Given this list of marker genes IGF1R, APBB2, SYNPO2, RIMS3, WSB2, LARP1B, TBC1D16, CBLB, ANKRD40, TBXT, ST3GAL3, ARL6IP5, CIRBP, KHDC4, IL13, DCUN1D4, BLOC1S5, RICTOR, NOS1, PRR3 (proline rich 3), NUP62CL, ARID2, KRAS, COL12A1, AASDH, PHIP, INO80D (NCBI Gene Id 54891), RTL5, ESYT1, BCL2L11 (BCL2 like 11), IKZF3, TANC2, ADGRL3, ARID4A (NCBI Gene Id 5926), PPP1R17, C15orf39, PPP1R10, GPATCH2L, ATXN2, ETS2, ALX4, RBM4B, PAPOLG, ACVR2B (NCBI Gene Id 93), ZCWPW2, IFRD1, PDZRN3, MCMDC2, PABIR1, ZNF280D, TSHZ2, AKAP1, TTI2, ELK4, DCTN5, RBFOX1, PHC3, TPD52L2, ZFX, VANGL2, TRIM44, SORBS1, CLK2, MIER3, PGAM1, SMIM20, CCDC6, ZG16, STXBP1 (NCBI Gene Id 6812), SYNCRIP, TMEM11, FREM2, HGF, TCN1, IDH3B, LRP4, ZNF547, here is a description of the gene set: from publication Chen Y, Wang X (PMID 31504780) Genes predicted to be targets of miRBase v22 microRNA hsa-miR-324-3p in miRDB v6.0 with MirTarget v4 prediction scores > 80 (high confidence targets). studied in species Homo sapiens Human Gene Set: MIR324_3P